The following is a description of a gene set: Human Gene Set: ZWANG_CLASS_1_TRANSIENTLY_INDUCED_BY_EGF species: Homo sapiens from publication Zwang Y, Sas-Chen A, Drier Y, Shay T, Avraham R, Lauriola M, Shema E, Lidor-Nili E, Jacob-Hirsch J, Amariglio N, Lu Y, Mills GB, Rechavi G, Oren M, Domany E, Yarden Y (PMID 21596316) Normal cells require continuous exposure to growth factors in order to cross a restriction point and commit to cell-cycle progression. This can be replaced by two short, appropriately spaced pulses of growth factors, where the first pulse primes a process, which is completed by the second pulse, and enables restriction point crossing. Through integration of comprehensive proteomic and transcriptomic analyses of each pulse, we identified three processes that regulate restriction point crossing: (1) The first pulse induces essential metabolic enzymes and activates p53-dependent restraining processes. (2) The second pulse eliminates, via the PI3K/AKT pathway, the suppressive action of p53, as well as (3) sets an ERK-EGR1 threshold mechanism, which digitizes graded external signals into an all-or-none decision obligatory for S phase entry. Together, our findings uncover two gating mechanisms, which ensure that cells ignore fortuitous growth factors and undergo proliferation only in response to consistent mitogenic signals. Class I of genes transiently induced by EGF in 184A1 cells (mammary epithelium)., and this is the list of marker genes: CCNL2, PDP2, NPHP3, SMAD3, AREG, FOXN2, SPAG5, LEKR1, IRF1, SNAPC1, RNU6-643P, RASSF8, TRIM50, CITED4, MAP2K3, SH3BP5, SEPTIN10, SPRY4, ATG101, PVR, AKAP13, OR10G7, RHPN2, SNORA70, B3GNT2, FBXO33, CBLB, SDCBP2 (NCBI Gene Id 27111), NRIP1, ZFP1, BMP2K, CCT6A, PSCA, MYO5B, DST, LINC00115, TAFA2, MIR503HG (NCBI Gene Id 84848), DUSP4, MAGI1, TNFAIP1, BACH1, ZNF217, DOCK5, TCAF1, RIPPLY1, LY6G6C, MOCS3, USP11, RNU1-72P, KCTD9, PHLDA2, RBMS1P1, ARHGEF3, GPRC5A, SDC4, TGFB2, SGK1, ERVK-28, COQ10B, LAMC2, RIGI, TIAM1, SHB, PIM1, ADRB2, ABRAXAS2, PIP5K1P1, RNU6-1274P, AGTR2, ATP2C2 (NCBI Gene Id 9914), SHISA6, IFFO2, ARL4C, TPBG, REEP3, PPAT, WDR35, PDCD1LG2, ABL2, INSIG2, STK17A, SERPINC1, SCARNA15, ENSG00000238485 (NCBI Gene Id 124905269), PRSS22, BEND7, B4GALT4, ARL15, RCAN3, JUND, TAF2, BBS9, MATN2, FOXD1, KCNJ15, NXT1, KBTBD2, KCNE1, PNPLA8, PCID2, ID1, KCTD9P3, TLR2, ZNF57, ARPP19, TRIM16, GLRA2, CBX4, CALD1, PTK2B, STK17B, DDX59, FAM83G, MYD88, RNU6-959P, PALLD, ANKRD28, SKIL, CREBZF, SH3RF1, UBE2H, CDK2AP1, PLAU, RPS8, TBPL2, LRIG2, AFDN, SERPINB2, RPS4Y1, CHD1, SRGAP1, MYO1E, CIBAR1P2, FNBP1L, LRRC8A, TEX36, OSBPL2, SLPI, CCNT1, HLA-DOA, EDN2, LRRC8C, CSRP1, SIPA1L2, RNU6-433P, BCL2L1, S1PR3, FOSL1, FAM210A, SLC36A2, CCN1, BBS10, LTO1, RAB39B, RNU6-926P, RHOB, CCDC68, COL4A1, PDLIM5, FABP3P2, LINC00319, COX6CP4, PGM2L1, TGFA, MBLAC2, DKC1, PTGER4, OTX2, RAB8B, IRF2BP2, RN7SKP296, MEG8, NEK7, RBAK, CNN2, GASAL1, ACAN, SNAI2, TCAF2, SEMA7A, ARFGAP3, RN7SL854P, MIR23AHG, MEF2D, SLC7A14, PTGER2, CIMIP4, BCL10, ARAP2 (ArfGAP with RhoGAP domain, ankyrin repeat and PH domain 2), PHACTR3, H2AC1 (H2A clustered histone 1), EEF2K, C10orf120, DENND2C, EREG, NEDD4L, MGAM, KBTBD4, FILIP1L, OSR2, TOLLIP, XCL2, NABP1, KRT16, STK40, MIR221, URGCP, LINC01341, TMEM131L, OXSR1, RUSC2, PABPC1P2, MFSD6, PSORS1C1, FHIP1A, CPNE8, PCDH7, KLF7, PARP12, ZFP36L2 (NCBI Gene Id 96706), ATP9A, TBC1D8, DDX55, ARL8A, LAMA3, SOCS6, ARHGAP23, NOC3L, MAP3K14, IRX3, IRS2, SULF1, AHR, BCAR3, VEGFC, RAB6A, ITGB6, RNF25, ITPKC, HAP1, OXTR, TNC, NUMBL, PARM1, MAT2A, RNF19A, NIPAL1, ERC2-IT1, TPM4, USP6NL, PTGER4P2, ACOT4, PARD6B, NEDD4, RNA5SP323, ELOVL7, ARSI, PLK3, RGMB, CRYBG2, SOCS2, MPRIP, GPRC5B, CRIM1, HUNK, PTMS, SSBP2, SLC19A2, SERTAD1, USP38, RPL7L1P19, RHPN1-AS1, EGR2, EPGN, CCNA1, FOXC1, SGMS1, SCHIP1, FMN1, ACKR3, IER5, HAS2, IL6ST, LBH, BCAR1, SDE2, ZNF281, ARHGAP21, NT5DC3, NRP1, PTPN1, RNF19B, DAPK3, GAPT, H4C4, CTBP2, SLC25A16, SNORD116-4, USP12P1, BCOR, ENO2, DOP1A, WDR1, ANOS1, IL20, PIM3, TRAF6, MIGA1, BIRC2, SLC26A2, SRD5A2, LDHAL6A, SINHCAF, PMAIP1, SLK, STAMBPL1, RPS6KA3 (ribosomal protein S6 kinase A3), RNU6-278P (NCBI Gene Id 106481767), LAMB3, LTA, ZNF800, ABHD2, SMCO3, SLC25A25, GRAMD2B, KCNH4, ADAMTSL2, ARID5B, EXT1, BNC1, DNAAF9, RNU6-461P, DCAF4, S100A16, BTG1, XCL1, CD274, ATF1, USP12, DLX2, RB1, GDF3, IL1R1, SPINK14, ENTPD7, CD244, RNU6-957P, CDV3, RNF217, RNU6-837P (NCBI Gene Id 106479936), ITGB8, EHD4, ADAMTS6, HSH2D, TSLP, ARL13B, EHD1, CAMK2D, SPRY2, ANGPTL4, TSC22D1, RNH1, RNASE8, DIPK1A, KCTD10, ITPRID2, ATP6V0A1, TBC1D2, ST3GAL1, SERPINB8, TMEM40, FHL2, FBXL3, GBP1, SYBU, CTSH, GPC2, GPRC6A (NCBI Gene Id 222545), MAK16, TOMM34, GABRQ, KLF6, PARP14, RNF212, NEDD9, NUFIP1, VEGFA, OPTC, EFNB2, VCL, HIPK3, DYRK1B, PRKAG2, SLC38A2, LIF, MARS2, ANKRD12, SH3TC1, GCLC, KLHL21, IL6R, UBE3A, AMOTL2, TMEM117, GRM4, ANKRD13A, SOCS5, AVPI1, JARID2, SYNJ2, PIP, EIF5A2, ZFP36, FBXO31, TAF5L, TUFT1, KIAA1217, RNU6-851P, TM4SF1, LIPG, SLC6A5, STK31, SDR16C5, THBS1 (thrombospondin 1), CHST15, CDCP1, CDK17, AGO4, EIF5, COL4A6, PRKCH, AHCTF1, PIP5K1A, LRCH1, GADD45B, AFF4, SLC12A7, PITX3, RNU6-411P, ATL1, HIF1A, NLRP4 (NCBI Gene Id 147945), IER2, MACIR, LDLR, PLCXD3, LYPD5, CACNG2, TRIM39, ARHGAP6, ADAMTS1, RNU6-799P, ACOX3, AGO2, RNU6-251P, OR4F15, RNA5SP156, ADAM17, VWA5B2, DUSP10, KIAA0513, PALM2AKAP2, DUSP7, IRX5, WRN, SRF, FRMD8, ING2, MYC, RASSF5, DIPK2A, AXIN1, ZFAND5, MET, LINC-PINT, MIR100HG, ACTBL2, ARHGEF2, RNA5-8SP4, LMAN1L, OSBPL3, AKAP12, MIDN, CAB39, RPS6KA5 (NCBI Gene Id 9252), CNN3, LRRFIP1, AQP3, CLDN12, ITGB1, DDIT4, RAPGEF5, LYN, PTP4A1P7, WDR75 (WD repeat domain 75, NCBI Gene Id 84128), SERPINB4 (serpin family B member 4), EEF1A1, SOX9, ADAMTS15, LRRC4, SUN1, SMOX, AKIRIN1, RNY3P7, BMAL1, GBP3, PPP1R2, ZNF557, MNT, ZNF536, SGTB, ZNF2, NFAT5, GADD45A, HYCC1, DNM1P47, MAPK6, FST, DGKD, NOCT, LINC01106, LINS1, L1TD1, HOMER1, SHROOM3, JUN, SHISA3, TPTE2P3, GRK6, GHSR, JAG2, POU5F1B, IFIT5, MIR17, RASSF9, PTX3, CSRNP2 (cysteine and serine rich nuclear protein 2), SAT1, CYTH1, LYST, BEST2, HERC3, CEP290, CSGALNACT2P1, PTPRE, DAAM1, TFAP2C, CEBPG, WTAP